Given this list of marker genes Akap6 (A kinase anchor protein 6), Dbt, Cpd, Rpgrip1l, Zfp937 (zinc finger protein 937), Pcdha5, Atp11c, Pcdha2, Agr2, Cdh4, 1700019A02Rik, Themis, Spata6, Pcdha6, Pcdhac1, H2-T24, Pcdha7, Pcdha1, Sh3gl2, Pter (NCBI Gene Id 99072), Ptbp3, Gtf2a2, Api5, Pcdha10, Abraxas2, Il3, Commd2, Pcdha3, B020004C17Rik, Usp32, Acad11, Me3, Lrrtm3, Clec4a4, Lnx1 (NCBI Gene Id 16924), Gpr37, Hhip, Duxf4, Erich5, Pcdha8, Pcdha4, Sema3a, Acvr1, Anxa3, Otc, Pcdha9, Bclaf3 (Bclaf1 and Thrap3 family member 3), Pcdha12, Fut10, Kpna4, Rnf149, Pcdha11, Syk, Nkain2, Or8g20, Gm15881, Pcdhac2, here is a description of the gene set: from publication Chen Y, Wang X (PMID 31504780) Mouse Gene Set: MIR_7241_3P Genes predicted to be targets of miRBase v22 microRNA mmu_miR_7241_3p in miRDB v6.0 with MirTarget v4 prediction scores > 80 (high confidence targets). studied in species Mus musculus